Given this list of marker genes Zfp57, Zfp513, Kmt2c, Rnf220, Zc3h14, Snai2, Enpp3, Ovol3, Zfp652, Rasa2, Cdadc1, Zfp932, Trhde, Zbtb48, Asxl2, Rnf223, Gata4, Zfp131, Zfp507, Car5a, Unc13a, Trps1, Zcchc17, Dgka, Zkscan3, P2rx2, Nhlrc1, Polr3a, Zbtb18, Zmynd10, Zfp800, Semg1, Clpx, Rasa3, Adh4, Zfp74, Pex10, Prkch (protein kinase C, eta), Sord, Cpa2, Tet2, Mt3, Cpm, Smap1, Usp19, Zfp92, Fbxo11, Rabif, Smap2 (small ArfGAP 2), Kmt2e, Rnf41, Mtf1, Rnf133, Rbck1, Matr3, Zscan21, Ino80b, Irf2bp1, Usp22, Mmp17, Zglp1 (NCBI Gene Id 100009600), Zbtb45, Anpep, Dnpep, Usp13, Pogz, Crip1, Foxp3, Lvrn, S100a5, Zfp654, Xrn2, Vat1, Fbxl19, Rara, Setmar, Esrrg, Rnf187, Wdfy2, Dctd, Herc2, Trim9, Zfp692, Sf1, Klf9, Trim26, Zfp821, Zfp3, Ttf2, Car2, Anapc11, Fnta, Spg7, Zfp27, Zfhx4, Ehmt1, Rnasel, Elof1, Msrb2, Myrip, Rigi, Suv39h1, Gata5, Kdm4c, Rbm22, Snai3, Ing3, Zfp574, Prkci, Deaf1, Smyd4, Dusp12 (NCBI Gene Id 98654), Pparg, Faap20, Klf3, Nufip1, Trim44, Ada, Svs3b, Dnajc21, Agap3, Smyd2, Zfand4, Zbtb8b, Trim31, Siah2, Vav2, Zfand2b (zinc finger, AN1 type domain 2B), Rxra, Klf16 (Kruppel-like transcription factor 16), Zfand2a, Gtsf1, Zfp82, Zfp58, Kat7, Nr2f1, Zfp526, Adam8, Prdm6, Trim46, Rasal1, U2af1, Git2, Zfp24, Traf1, Zswim8, Rnf19a, Zgpat, Prdm10, Traf3, Dus3l, Ptgr2, Aars1, Glo1, Zfp329, Snca, Rnf217, Mmp16, Zfp618, Mta2, P2rx4, Dtx2, Tcea3, Fhl3, Zxdc, Zfp580, Slc11a2, Zfp532, Zcwpw2, Dnaja1, Ubr1, Zcchc4, Snrpc, Abcc8, Smyd3, Unc13c, Hdac10, Cit, Traf2, Znhit2, Zfp36l1, Zfp667 (zinc finger protein 667), Phf1, Zc2hc1a, Rc3h1, Car12, Bbox1, Nr5a1, Zfp689, Rnf146, Lnpk, Prkcz, Cbll1, Neurl1a, Kdm5c (NCBI Gene Id 399585), Arhgap45, Polr2k, Zbed4, Zfp462, Usp33 (NCBI Gene Id 99490), Zfp474, Esrrb, Adamts2, Rps29, Hinfp, Zbbx, Zhx3, Zbtb6, Zfp64, Zbtb46, Mbnl2, Trim28, Zscan4d, Rbm26, Agfg2, Bspry, Zfyve26, Prkca, Nr1d2, Alb, Tars1, Dgkz, Pclo, Mid2, Clip1, Patz1, Dnmt3b, Supt4a, Dgkb, Rbm10, Tut7, Zfp521, Dtnb, Car6, Zfp704, Trim24, Rnf225, Nr2c2, Zzef1, Adh6a, Zic5, Klf1, Trim11, Gtf2e1, Nudt3, Klf2, Zfyve9, Brd1, Taf1b, Peg10, Dnmt1, Zxdb, Nr6a1, Ttc3, Thap11, Zar1l, Polr1h (RNA polymerase I subunit H), Phf14, Zfp277, Prkce, Fhl5, Aptx, Capn15, Fancl, Rchy1, Rnf149, Cdc42bpg, Svs3a, Dpys, Zcchc18, Trim35, Runx1t1, Trim27, Shank3, Nr5a2, Nploc4, Baz2a, Supt4b, Lhx5, Chd5, Ubr7, Usp5, Tesl1 (testin LIM domain protein like 1), Mios, Zfp683, Uhrf1, Champ1, Srek1ip1, Fhl1, Prkcg, Rxrb, Fbxo5, Ehmt2, Agtpbp1, Rag1, Fus, Znhit3, Rnf185, Lnpep, Rad18, Gda, Zfp365, Zzz3, Nr4a1, Vav3, Rnf145, Adamts15, Znrf1, Adamts8, Zfp771, Ube3a, Rnf5, Dgkh, U2af1l4, Rbm5, Ankfy1, Zfp385c, Zranb3, Phf10, Nbr1, Rnf170, Bcl6, Irf2bpl, Rnft2, Zfp354c, Smpdl3b, Fgd3, Ep300, Gtf2b, Nr1i2, Rbm4b (NCBI Gene Id 66704), Znhit6, Neil2, Traf7, Zc3h12d, Marchf6 (membrane associated ring-CH-type finger 6), Sytl3, Zrsr2, Rnf144b (ring finger protein 144B), Prickle3, Parp12, Morc2b, Zfp30, Tab2, Mkrn2, Usp39, Pggt1b, Maea, Dpf1, Ighmbp2, Car10, L3mbtl3, Zfp827, Stac3, Adat2, Sprtn, Zfp182, Rasgrp1, Zfp672, Rspry1, Napepld, Thap1, Pdzrn3, Chd4, Rpl37, Rnf6, Sap30l, Sall4, Mex3c, Fhl2, Jade2, Zfp318, Zfp687, Foxp1, Fbxo40, Zfyve27, Fan1, Zfp568, Kdm3b, Trim39, Bcl11a, Dzip1, Dgkq, Dnajc24, Zfp511, Gmip, Zfp46, Rnf20, Zfp143, Zmat4, Msrb1, Zfp335, Zbtb32, Zc3h12c, Zfp473, Znfx1, Ovol2, Zfp770, Zfp28, Cpd, Cblc, Fgd6, Ptms, Phc2, Plekhf2, Zkscan6, Polr2i, Rnf152, Zcchc12, Zfp639, Polr1b, Gzf1, Zswim1, Zfp59, Mcm10, Rnf115, Zscan4f, Alad, Rc3h2, Klf4, Zfp804a, Traf4, Tank (NCBI Gene Id 97021), Zfp316, Rest (RE1-silencing transcription factor), Zfp423, Rtp3, Vdr, Rapsn, Zfp608, Dtx1, Tax1bp1, Nudt12, Cpa4, Plekhf1, Zc3h12a, Tada2a, Zfp2, Apobec1, Myo9b, Alpi, Hdac6, Mmp25, Trim36, Zfp609, Arap2, Zfp112, Dclre1a (NCBI Gene Id 80616), Plscr1, Mmp3, Jmjd1c, Morc1 (microrchidia 1), Zfp12, Pole, Akp3, Zfyve16 (zinc finger, FYVE domain containing 16), Cxxc1, Zfpm1, Rbm27, Tnp2, Zfr, Rtn4ip1, Ppard (peroxisome proliferator activator receptor delta), Fiz1, Rnf125, Trim8, Agfg1, Rufy2, Zfp54, Polr2l, Wrnip1, Sirt2, Car1, Mmp10 (matrix metallopeptidase 10), Bard1, Zfp865, Helz2, Zfp319, Pglyrp3, Hif1an, Trim63, Rfpl4, Zfyve19, Atxn7l3, Otud7a, Stac2, Sp1, Snai1, Nr2f6, Zbtb22, Mmp24, Chn1, Smpdl3a (NCBI Gene Id 70336, sphingomyelin phosphodiesterase, acid-like 3A), Trim13, Gata6, Bmi1, Mmp23, Chn2, Drp2, Timp2, Mybbp1a, Rnf183, Rasgrp4, Fam170a, Fezf2, Nr2c1, Zfhx2, Yy2, Trmt13, Zranb2, Trerf1, Mex3b, Rnf114, Zfp524, Acmsd, Kdm2a, Esco1, Pde2a, Rorc, Qtrt2, Ppara, Myt1l, Sp6, Ide, Traf5, Trim62, Tiparp, Aicda, Zcchc7, Ikzf1, Acap1, Ankzf1, Zfp426, Zfp41, Nob1, Zc3h4 (zinc finger CCCH-type containing 4), Bhmt, Zfp354b, Trim10 (tripartite motif-containing 10), Insm2, Zfp69, Lnx2, Zfhx3, Zfp276, Grin2a, Zkscan1, Tdrd1, Sec24c, Zfp330, Eri2, Gli1, Gatad2a, Esco2, Calb1, Prdm12, Rnf126, Rnf112, Sall3, Vav1, Thra, Zmynd15, Sirt3, Zbed6, Ebf4, Arhgef18, Zbtb49, Egln1, Tut1, Pcgf3, Rnf222, Prr3, Asxl3, Pglyrp4, Zfand5, Zcwpw1, Pdzd8, Pikfyve, Rnf24, Crebbp, Zfp575, Zbtb3, Rnf169, Sp4, Baz2b, Tll1, Gata1, Zfp281, Trim32, Ranbp2 (RAN binding protein 2), Dnmt3l, Zfp711, Pld6, Zfp91 (NCBI Gene Id 67567), Yaf2, Kdm5d, Hltf, Rnf208 (ring finger protein 208), Arap1, Syvn1, Klf8, Zfp488, Uba5, Zfp385a, Car7, Gfi1b, Tec (NCBI Gene Id 21682), S100a13, Trim71, Zc3h6, Sec23a, Slfn9, Klf14, Cd4, Birc7, Kat6b, Zfp809, Aebp2 (AE binding protein 2), Nup42, Bhmt2 (NCBI Gene Id 97887), Pitrm1, Brf1, Zfp410, Car11 (NCBI Gene Id 12348), Cpa1, Dtx4, Gli2, Klf10 (Kruppel-like transcription factor 10), Zfp637, Cop1, Rgn, Tbkbp1, Nos1, Rnpep, Zic4, Acer3, Zfp1, Adamts20, Zmiz2, Pja2, Sharpin, Zfp120, Trafd1, Tshz3, Smyd5, Zfp646, Zbtb41, Rnpepl1, Trim38 (tripartite motif-containing 38), Rffl, Pcgf6, Scrt1, Phf12 (PHD finger protein 12), Nr1h3, Fgd1, Zbtb43, Marchf4, Grin2b, Cul9, Rph3al, Prickle2, Yod1, Mbd1, E4f1, Dzip1l, Zfp518a, Zfp382, Wt1, Zfp445, Sec24b, Akap8l, Zfp516, Kdm7a, Fyco1, Slx4, Zbtb7c, Thap12, Glis3, Ddah1 (NCBI Gene Id 99881), Jade1, Rorb, Zfp536, Usp45, Smpd1, Vps18, Cbl, Ebf1, Marchf3, Msrb3, Zfp26, Apobec3, Nsmce1, Enpp5, Rnft1, Vps41, Cxxc4, Rnf31, Lactb2, Zhx1, Pla2g15, Fezf1, Ubr3, Marchf11, Ksr1, Trim25, Trim45, Apip, Kcmf1, Insm1, Zfp346, Usp49, Trim7, Top3a (topoisomerase (DNA) III alpha), Blvra, Zmat5, Klf7, Agbl2, Zfp106, Afg3l1, Plag1, Traf6, Ankmy1, D2hgdh, Rlim (ring finger protein, LIM domain interacting), Fbxo43, Klf6, Car4, Osr2 (odd-skipped related 2), Cpa3, Acap2, Gcm1, Ifih1, Zeb2, Slc4a8, Rnf26, Eea1, Mtmr4, Zfp664, Upb1, Trmt44, Lyar, Setdb1, Tns2, Dnlz, Phf21b, Car13, Unkl, Fgd4, Rabggtb, Rbm4, Sec23b, Adh1, Nr1h2 (nuclear receptor subfamily 1, group H, member 2), Prkd2, Rnf139, Bhmt1b, Zfpm2, Zswim4, Kdm5a, Timp4, Arfgap3 (NCBI Gene Id 75390), Zfp706, Trim42 (NCBI Gene Id 78911), Pglyrp1, Cxxc5, Sobp, Trim17, Slu7, Toe1, Tshz1, Zc3h11a, Rmnd5a, Myt1, Mynn, Rtl3, Zcchc24, Taf3, Nr2e1, Znrf3, Wdfy1, Trim66 (NCBI Gene Id 330627), Zfyve1, Pold1, Hivep1, Arfgap1, Glis1, Repin1, Ccnb1ip1, L3mbtl4, Nr2f2, Zfp263, Hivep3, Git1, Zbtb5, Bcl11b, Asap3, Unk, Tab3, Lnx1, Zfp128, Birc3, Timp1, Egr2, Usp51, Cbfa2t3, Sytl5, Atrx, Arid2, Zfp414, Lims1, Dnaja4, Pam, Cnot4, Rph3a, Marchf8, Adamts5, Nr1i3, Blm, Metap1, Agbl5, Zcchc10, Zscan4c, Rictor (NCBI Gene Id 78757), Klf15, 4931406C07Rik, Mmp20, Mmp9 (matrix metallopeptidase 9), Mlph, Trim54, Kdm2b, Brpf3 (bromodomain and PHD finger containing, 3), Zmat1, Nqo2, Agbl4, Ints12, Phf8, Ubr2, Rnf214, Zbtb42, Kat6a, Ddx59, Rnf7, Rnf212b, Trim23, Zfp207, Atf7, Prdm9, Zbtb33, Nr3c1, Dpf2, Cyld, Ovol1, Zfp775, Nr3c2, Rnf224, Prickle1, Rnf168, Prim1, Zfp422, Zswim3, Rnf148, Zfp746, Zc3hav1, Phf2, Mta3, Lin28b, Sqstm1, Ace, Lancl1, Dcst1, Prdm14, Vps11, Zswim5, Esrra, Mpi, Pglyrp2, Mycbp2, Prmt3 (NCBI Gene Id 71974), Xiap, Rora, Mbnl3, Jade3, Nr4a3, Rnf123, Zfp326, Zfp184, Asah2, Zcchc9, Czib, Zfp142, Rmnd5b, Lonrf3, Trim65, Rims1, Zfp661, Trim47, Mgrn1, Rreb1, Churc1, Atmin, Zfp14, Gata3, Brf2, Adh6b, Phc1, Rpl37a, Arih1, Zic1, Gch1, Adamts1, Parp1, Nr1d1, Rasgrp2, Car3, Zfp593, Pola1, Zcchc14, Zfp11, Zfp551, Rnf216, Kin, Rnf213, Galt, Phf11d, Zmynd19, Tnfaip3, Lonrf1, Tmem163, Trim56, Atf2, Hhip (NCBI Gene Id 56864), Ikbkg, Zcrb1 (NCBI Gene Id 67197, zinc finger CCHC-type and RNA binding motif 1), Mib2, Shh, Slc30a7, Pnma3, Rnf215, Samhd1, Prkcd, Plekhm1, Rnf180 (NCBI Gene Id 71816), Plscr2, Mmp13, Mdm2, Trim40, Pter, Morc3, Zfp879, Rassf1, Zmym4, Eif2s2, Nt5e, Trim75, Mnat1, Zfp598, Pcgf2, Hrg, Rock2, Trim34b, Zfpl1, Zcchc2 (zinc finger, CCHC domain containing 2), Rims2, Rai1, Usp16, Glis2, Astl, Arhgef2, Wiz, Sirt4, Sp5, Topors, Zswim2, Ctcfl, Zc3h18, Ddx41, Trim50, Itpr3, Mt1, Hic2, Prdm1, Rnf128, Cdc42bpb, Ebf3, Ring1, Zscan2 (NCBI Gene Id 22691), Myo9a, Zfp553, Zfp239, Mmp1b, Dtx3l, Litaf, P4htm, Itgb1bp2, Mmp11, Mex3d, Mtmr3, Rnf144a (ring finger protein 144A), Rnf25, Rps27a, Zmynd11, Ing4, Rpain, Trip4, Rnf38, Rufy1, Trim43c, Rxrg, Zc3h3 (NCBI Gene Id 245129), Cad, Egr4 (early growth response 4, NCBI Gene Id 13656), Zar1 (zygote arrest 1), Sirt6, Rbak (NCBI Gene Id 57782), Rnf121, Lrsam1, Zfp39 (NCBI Gene Id 22698), Zfp367, Wdr59, Zfp622, Zfx, Dzip3, Trim6, Npepps, Stac, Tmem129, Ptpn1 (NCBI Gene Id 19246), Asap1, Zfp740, Zfp60, Aars2, Leng9, Hic1, Phf7, Zcchc8, Enpep, Ikzf4, Trim43a, Zfp458, Kat5, Mul1, Klf5, Mtr, Zc3h10, Pml, Polr3k, Rnf19b, Agap2, Mmel1, Car15, Rnf166, Hr, Zbtb14, Esr1 (estrogen receptor 1 (alpha)), Hdac4, Nr4a2, Phf23, Rufy4, Bnc2, Zbtb4, Ash2l, Zfp280c, Gata2, Rtp2, Calcoco1, Zbtb9, Zfp691, Tk1, Prkd1, Prkcb, Mmp1a, Ptgr3, Trim43b, Zfp37, Trim33, Msl2, Mcm2, Zfp710, Sytl4, Cpsf4, Zfp110, Utrn, Trim34a, Zcchc3, Zfp451, Trim41, Pygo1, Siah1a, Dmd, Siah1b, Trmt1l, Rnf167, Zc3hc1, Zfp703, Ins2, Phf5a, Maz, Setdb2, Bmx, Zfp579, Kmt2a (lysine (K)-specific methyltransferase 2A), Zfp369, Ptch1, Rbbp6, Vps8, Egr1, Rnf43, Flywch1, Zfp653, Bsn, Rnf227 (NCBI Gene Id 80515), Tet3, Snrnp48, Mtf2, Rtp4, Prm2, Gatad2b, Primpol, Nsd2, Esr2, Zfp518b, Nsd3, Zfp322a, Klf11, Usp44, Arfgap2 (NCBI Gene Id 77038), Thap7, Marchf1, Ark2c, Zfp36, Zfp36l2, Alkbh8, Rnf34, Trit1, Trim72, Zfat, Zkscan17, Kat8, Morc2a, Sall1, A430033K04Rik, Cpxm1, Trim3, Triml1, Trim69, Rtp1, Zhx2, Mkrn1, Rarb, Hivep2, Peg3, Sh3rf1, Fbxo30, Sh3rf2, Sp7, Zfp750, Ikzf5, Hnf4a, S100a6, Ar, Pex2, Zftraf1, Zmat2, Neurl3, Lin28a, Bfar, Dgkd, Aopep, Fgd2, Neil1, Dgkg, L3mbtl2, Trmt1, Mss51, Rnf135, Dnaja3, Zmym2, Pan3 (NCBI Gene Id 72587), Cpxm2, Sec24d, Dpp3, Klf12, Agap1, Smyd1, Znrf2, Zpr1, Brca1, Zfyve28, Nanos2, Upf1, Gtf2h3, Foxp4, Zscan26, Rnf212, Rnf10, Apex2, Bmp1, Adamts4, Zfp583, Cbfa2t2, Smad3, Nanos1, Zfp148, Mep1a, Nsmce2, Rnf40 (NCBI Gene Id 233900), Dnaja2, Dpep1, Rock1, G2e3, Rnf13, Zbed3, Marchf2, Dtx3, Zbtb8a, Xpa, Ing2, Zc4h2, Gtf3a, Tshz2, Bcl6b, Dnmt3a, Trim12a (tripartite motif-containing 12A), Rpa1, Egr3, Slx1b, Mep1b, Suv39h2, Phrf1, Tet1, Tcf20, Lta4h, Phf13, Zfp629 (NCBI Gene Id 320683), Ubr5, Nsd1, Kdm3a, Lmcd1, Marchf5, Zfp62, Mmp19, Tnip2, Usp3, Hgs, Raf1 (NCBI Gene Id 76876), Siva1, Phc3, Rnf8, Zscan20, Wdfy3, Mt2, Zc3h13, Rnf103, Racgap1, Dido1, Sap30, Zfand3, Btk (Bruton agammaglobulinemia tyrosine kinase), Neurl1b, Cnbp, Eprs1 (glutamyl-prolyl-tRNA synthetase 1), Nanos3, Adap2, Rnf2, Ltn1, Rassf5 (Ras association (RalGDS/AF-6) domain family member 5), Pja1, Birc2, Car14, Nfx1, Mbnl1, Rnf17, Sall2, Phf24, Rnf122, Zfp668, Ksr2, Baz1b, Zmym3, Zfyve21, Erap1, Gatad1, Obi1, Zfp428, Enpp2, Mib1, Mbtd1, Thap4, Cdo1, Rnf11, Zc3h8, Brpf1, Polr2b, Ece1, Kdm5b, Suz12 (SUZ12 polycomb repressive complex 2 subunit), Irf2bp2, Helz, Trim16, Sh3rf3, Lhx3, Zic2, Phf11a, Kmt2b, Rnf151, Car5b, Traip, Dgke, Ski, Gpatch8, Cgrrf1, Nr2e3, Adam33, Zbtb17, Zbtb7b, Zfand1, Zfp93, Rnf130, Cryz, Nr1h4, Prdm16, Zc2hc1b, Cpb2, Cpa6, Arhgap29, Polr3b, Zfy1 (zinc finger protein 1, Y-linked), Ubox5, Aebp1, Otud7b, Aire, Prdm4, Mta1, Zbtb44, Ikzf2, Zmiz1, Zfp787, Rbsn, Wbp4, Fntb, Chfr, Rps27, Dzank1 (NCBI Gene Id 99097), Timm8a1, Zfp296, Rtl4, Lhx4, Mmp14, Mmp21, Zfp366, Gtsf1l, Pdxk, Kdm4b, Polh, Prdm8, Zfp146, Rnf111, Trim68, Qpct, Prkn, Rnf14, Zkscan5, Dpf3, Pdcd2, Kdm4a, Phf19, Iscu (iron-sulfur cluster assembly enzyme), Mllt10, Cpa5, P2rx7, Mmp2, Gli3 (GLI-Kruppel family member GLI3), Rabgef1, Zfp523, Zfp641, Adh5, Cdkn1a (NCBI Gene Id 12575), Glra1, Tut4, Rnf181, Prkd3, Sf3a2, Cpz, Ctcf, Sp3, Zeb1, Sod1, Polr2a, Znrf4, Amfr, Rag2, Lhx1, Zfp36l3, Zc3h15 (NCBI Gene Id 72497), S100b, Lig3, Ing1, Rbx1, Zfp354a, Prdm5, Zik1, Map3k1, Arhgef28, Zmym5, Prkcq, Ppp1r10, Fgd5, Zfp42, Zfp784, Zbtb20, Srsf7, Zfp647, Gfi1, Usp20, Ankib1, Agbl3, Casz1, Mecom, Thap3, Rpap2, Zscan10, Dtna, Car8, Zswim6, Kdm1b, Mme, L3mbtl1, Pias1, Trim58, Neil3, Zfand6, Dhx57, Sp9, Zfp786, Zfp418, Dhx58, Rnf186, Zscan12, Zbtb11, Trim60, Mdm4, Sf3a3, Brap, Sirt5, St18, Pias4, Adnp2 (NCBI Gene Id 71470), Zbtb1, Prdm15, Zfp830, Adamts9, Osr1, Adh7, Zfp90, Timp3, Zfp219, Uimc1, Zfp697, Xaf1, Wdr24, Ebf2, Zfp592, Tnks, Tnfsf10, Bnc1, Ing5, Zup1, Scnm1 (sodium channel modifier 1), Rnf4, Ubr4 (ubiquitin protein ligase E3 component n-recognin 4), Prdm13, Optn, Zfp512, Trim21, Zfp385b, Agbl1, Naaladl1, Zfp292, Plekhm3, Aplf, Zc2hc1c, Trim30a, Phf20, Baz1a, Rnf207, Rere, Phf6, Klf13, Trip12, Zmynd8, Cblb, Zdhhc20, Trim29, Sp2, Slfn8, Tes, Zfp280d, Arih2, Marchf7 (membrane associated ring-CH-type finger 7), Chordc1, Litafd, Mmp7 (NCBI Gene Id 17393), Yy1, Mmp12, Mmp8, Ash1l, Dytn, Pcgf1, Rnf141, Zc3hav1l, Rnf182, Ikzf3, Atp7b (NCBI Gene Id 11979), Mmp15, Zfp13, Morc4, Zfp260, Zranb1, Araf (NCBI Gene Id 80437), Gtf2h2, Foxp2, Mkrn3, Mefv, Zswim7, Zbtb7a (NCBI Gene Id 71606), Marchf9, Zfp628, Trim2, Car9, Sp8, Rasa4, Enpp1, Ewsr1, Scrt2, Tesl2, Shprh, Dbf4, Zfp35, Phf20l1, Phf21a, Polr1a, Mid1, Rbm20, Rabggta, Sec24a, Trim67, Slc39a4, Zmat3, Pias2, Pex12, Tcea1, Rnf150, Qpctl, Zfp768, Rarg, Klf17, Zfp638, Trim37, Rybp, Rnf44, Rnf32, Rp9, Cda, Rnf138, Vat1l, Polk, Zfp503, Zdhhc15 (zinc finger, DHHC domain containing 15), Zgrf1, Zfp467, Akap8, Kmt2d, Akap13, Def8, Zkscan14, Mylip, Tll2, Znhit1, Adnp, Trim14, Cdip1, Hnf4g, Trim59, Rps27l, Cpn1, Zbtb24, Thrb, Enpp7, Asxl1, Zic3, Rev3l, Ears2, Cdc42bpa, Nup153, Birc5, Pias3, Zfp541, Thap2, Cpe, Rnf157, Jazf1, Tns1, Pgr, Afg3l2, Zfy2, Itk, Dhh (NCBI Gene Id 97964), Tcea2, Unc13b, Zfp287, Ankmy2, Pcgf5, Recql4, Uhrf2, Rfwd3, here is a description of the gene set: Binding to a zinc ion (Zn). Mouse Gene Set: GOMF_ZINC_ION_BINDING studied in species Mus musculus